The following is a description of a gene set: Endonucleolytic cleavage between the SSU-rRNA and the 5.8S rRNA of an rRNA molecule originally produced as a tricistronic rRNA transcript that contained the Small SubUnit (SSU) rRNA, the 5.8S rRNA, and the Large SubUnit (LSU) rRNA, in that order, from 5' to 3' along the primary transcript. studied in species Homo sapiens Human Gene Set: GOBP_ENDONUCLEOLYTIC_CLEAVAGE_IN_ITS1_TO_SEPARATE_SSU_RRNA_FROM_5_8S_RRNA_AND_LSU_RRNA_FROM_TRICISTRONIC_RRNA_TRANSCRIPT_SSU_RRNA_5_8S_RRNA_LSU_RRNA, and this is the list of marker genes: RCL1, RPP40, KRI1, NOP9, UTP20, FCF1, NOP14, RRS1, ABT1, RPS21